The following is a description of a gene set: Human Gene Set: GOBP_CHOLANGIOCYTE_PROLIFERATION The multiplication or reproduction of cholangiocytes, resulting in the expansion of the cholangiocyte population. A cholangiocyte is an epithelial cell that is part of the bile duct. Cholangiocytes contribute to bile secretion via net release of bicarbonate and water. studied in species Homo sapiens, and this is the list of marker genes: PKHD1, HDAC6, GPBAR1, LIMS2, NOTCH2